Given this list of marker genes DZIP1, DVL2, ZFYVE26 (NCBI Gene Id 338378), B3GNT9, CYP2D6, PSME3, IRF9, NEUROD1, VGF, RPS2, SLC25A32, HOXA7, NPM1, SUCLG2, TCOF1, CARMIL3 (NCBI Gene Id 90668), ZC3H10, PSME3IP1, CPT1A, NRIP3, BCAS3, ESRP2, TOPORS, ANKRD12, FOXO3, SNX5, BOK, METAP1D, GLYR1, SIGMAR1, ETV1, OGDHL, ATP6V1A, QTRT1, ZNF503, AP1S2, MIA2, IGF2BP1, PCED1A, NFX1, UBR4, CDK5R1, UBXN10, MTHFD1, HNRNPA1, GPX1, PPP1R3C, KLHL28, BAX, VPS16, PTGES2, ALDH6A1, MXD4, CFL1 (cofilin 1), STMN1, ANKHD1, SUMF1 (NCBI Gene Id 285362), UBE2B, GUCY1A2, EME1, ILF3, CD164 (NCBI Gene Id 8763), DUSP1, POGK, PPRC1, LZTS2, GAPDH, TUBA4B, BRDT (bromodomain testis associated), ELAVL3, FOXD3, AMPD2, GET3, RCOR2, ANAPC13, FKBP11, EIF4B, PDIA4, EPB41L4B, HBP1, TMEM258, KCNE4, GTF2H1, CAD, FGF14, TUBA4A, SRP72, CIPC, RUNX2, ZCCHC7, HOXD10, IQGAP2, HOXC5, VPS37B, CBX5, TOGARAM1, RBM15B, SHOC1, IPO13, GNAS (GNAS complex locus), PHF20L1, NMNAT2, HOXB5, ATP6V1C1, NAA50, DENND6A, NPTX1, PLEKHA6, SSR1, GJA1 (NCBI Gene Id 7953), SMAD2, SLC38A5 (solute carrier family 38 member 5), MTCH2, ACAP3, HOXB7, FEN1, SYNCRIP, CCNYL1, NOL4L, DDX3X, MANF, MAX, TCF4, PA2G4, EPB41, SNTB2, CPEB4 (NCBI Gene Id 80315), NUP62CL, PLCG2 (NCBI Gene Id 5336), AMMECR1L, PFDN2, GIT1, CSK, BMP6, RAI14, AGO2, LIN28A, IRS4, ATXN3, MEOX2, PPM1A, PHF20, GATA5, ATOH8, PICALM, IGSF22, KCNH4, KBTBD2, LZTFL1, EIF3A, MGME1, SMC3, ADAMTS17, OPRD1, SLC1A7, EIF4E, SIRT1, SPNS1, ANKHD1-EIF4EBP3, ILF3-DT, C1orf43, PRKCG, HMGA1, TFRC, FGF6, CSDE1, RAB3IL1, DSCAM, TESK2, MAT2A, AATF, SYT3, DNAJB5, KLF11, TIMM8A, SEC11C, ZBTB10, DNMT3A, UBR5, LAMP1, MON1A, EPC1, SNCAIP (NCBI Gene Id 9627), TCERG1, SCRT2, AKAP1, COPZ1, PCDHA10, ACY1, STEEP1, XPO1, ARMT1, HOXA11, DUSP7, BATF3, ADSS2, TFAP4, KANSL1L, KMT2A (lysine methyltransferase 2A), MRPL40, THUMPD2, SEPTIN3, SERBP1, DNAAF6, SLC38A2, ATF4, UBE4B, CHD4, DHX35, BEND4, TMEM108, NDUFS1, HHEX, SLC31A2, NOTCH1, RALYL, PRPS1, HIRA, PABPC1, COMMD3, USP15, CCDC191, RMND1, SUPT16H, PRKCH, PDK2, TGFB2, ZNF318, BCOR, LONRF3, EN1, CEP63, GNB2, RCL1, DYM, SLC25A31, DCAF13, HPS5, HAPSTR1, ODC1, MRPL27, AKAP12, NUDC, NIT1, ATF7IP, SLC26A2, GGN, TAF6L, DERL3, PER1, PTMA, QTRT2, CLN3, ADAMTS3, RSPRY1, DEPDC7, TIMM10, REXO2, HOXC11, EEF1B2, TOP1, CACUL1, RLF, CCAR1, KICS2, PRDM4, here is a description of the gene set: Genes having at least one occurrence of the motif NNANCACGTGNTNN in the regions spanning 4 kb centered on their transcription starting sites. This matches the MAX transcription factor binding site V$MAX_01 (v7.4 TRANSFAC). Human Gene Set: MAX_01 species: Homo sapiens